The following is a description of a gene set: Mouse Gene Set: GOBP_NEGATIVE_REGULATION_OF_TOLL_LIKE_RECEPTOR_4_SIGNALING_PATHWAY Any process that stops, prevents, or reduces the frequency, rate, or extent of toll-like receptor 4 signaling pathway. species: Mus musculus, and this is the list of marker genes: Ticam2 (TIR domain containing adaptor molecule 2), Trem2, Rab7b, Bpifb1, Acod1, Nr1d1, Mfhas1, Lyn, Tax1bp1, Dab2ip, Trim32, Sqstm1